The following is a description of a gene set: TWIK related alkaline pH activated K+ channels are activated by increase in the extracellular pH. TALK1 and TALK 2 are members of the TALK subfamily and are both are activated by rise in extracellular pH. TALK 2 is expressed in proximal tubule cells and collecting duct cells. TASK 2 is involved in the resorption of bicarbonate. studied in species Homo sapiens Reactome Pathway: TWIK-related alkaline pH activated K+ channel (TALK) part of: Tandem pore domain potassium channels, and this is the list of marker genes: KCNK16, KCNK17